Given this list of marker genes CASR, JAK2, LACC1, UNC93B1 (NCBI Gene Id 81622), IL2RG, ANKRD26, PRSS2, TP53, ARPC5, CFTR, PRSS1, SLC35C1, SHARPIN, SRSF2, TRPV6, NLRP12, DCLRE1C, CYP27B1 (NCBI Gene Id 5135), STAT3, PRKAR1A, STAT2 (signal transducer and activator of transcription 2), TBK1, AP1S3, CDH23, TICAM1, CBL (Cbl proto-oncogene), PIK3CD, IL7R, RMRP, NPM1 (nucleophosmin 1), OSTM1, ZPR1, TET2, GATA1, TGFB1 (transforming growth factor beta 1), PSMB9, HMGCL, NABP1, CYP2R1, TRAF3, RUNX1, CHD7, CASK, SALL4, MPL, PKHD1, IFNG, BCOR, DOCK11 (dedicator of cytokinesis 11), MVK, SPINK1, IL36RN, ATRX, USP8, IL37, FERMT3, USP48, HBB, AGR2, IFNGR1, RAC2, RARA, LIG4, ADA, RBM8A, SF3B1, BCR, XRCC4, RAG2, STAT5B, TBL1XR1, LPIN2, ITGB2, CALR, NUMA1, TTC7A, IKBKG, TNFRSF1A, MICU1, ACAT1, RAG1, REL, OTULIN, NR3C1, IRF2BP2, BRAF, PML, FIP1L1, ADA2, ZBTB16, ABL1, CPA1, NLRP3, CTRC, TLR3, SH2B3, OAS1, KIT, LYN, NHLRC2, PTPN6, MEFV, ASXL1, RBCK1, G6PD, GATA2, here is a description of the gene set: species: Homo sapiens An abnormal increase in the number of leukocytes in the blood. Increased total leukocyte count Human Gene Set: HP_INCREASED_TOTAL_LEUKOCYTE_COUNT